Given this list of marker genes ZDHHC7, SMAD5, SP100, MIR27A, TMBIM1, MIR23A, here is a description of the gene set: species: Homo sapiens Any process that modulates the frequency, rate or extent of Fas signaling pathway. Human Gene Set: GOBP_REGULATION_OF_FAS_SIGNALING_PATHWAY